The following is a description of a gene set: Human Gene Set: HP_ABNORMALITY_OF_THE_RADIOULNAR_JOINTS Abnormality of the radioulnar joints species: Homo sapiens, and this is the list of marker genes: SCARF2, TRPV4, CANT1, POR, AEBP1